The following is a description of a gene set: studied in species Mus musculus Mouse Gene Set: MIR_7A_2_3P from publication Chen Y, Wang X (PMID 31504780) Genes predicted to be targets of miRBase v22 microRNA mmu_miR_7a_2_3p in miRDB v6.0 with MirTarget v4 prediction scores > 80 (high confidence targets)., and this is the list of marker genes: Hnrnph2, Yae1d1, Lrrtm3, Fbn1, Ippk, Hoxb5, Lancl2 (LanC (bacterial lantibiotic synthetase component C)-like 2), Phkb, Atp6v1g1, Ro60, Rtn3, Nusap1, Ercc3, Ttc8, Hoxa5, Dnajc12, Hycc1, Cyct, Cited2, Gpr174, Krtap13-21, Slain2, Ddi2, Col19a1, Nufip2, Supt4a, Chst2, Gfral, Skil, Tmem11, Agfg1, Pcdh9, Son, Nfya, Ssh2, Smad1, Heyl, Slc35a3, Fam117b, Myo5c, 2210408I21Rik, Dr1, Olig2, Mtdh, Hnrnpf, Atp2b1, Atg2b, Trim33, Ncam1, Kifbp, Ret, Slc66a2, Ccdc80, Fgd4, Erlec1, Vma21, Dusp22, Pitx2, Tcf7l2, Rpn2, Myocos, A830018L16Rik, Sco1, Thsd7a, Asap2, Pnkd, Arf1, Epc1, Tmed2, Gpr17, Zfp608, Ica1l, Zswim6, Zmynd15, Pdzrn3, Cnot6, Ankib1, Prkd1, Rnf6, Fam169a, Ppp1r9a, Rps6ka5, Zfp26, Arpc2, Nrbp1, Mbnl1, Zfp945, Akr1c19, Rapgef6, Arhgef6, Rbm26, Cth, Crebzf, Hook3, Rora, Pbrm1, Tpd52, Scaf8, Srsf2, Dppa3, Hs3st1, Cst5, Neo1, Slmap